Given this list of marker genes KLF10, SGK1, TGIF1, TRIM13, ACKR4, RRP12, NXF1, HBA2, RMDN3, AREG, CD52, SRA1, PADI3, C9orf40, TMPRSS2, TCP10L, GJB3, DNAJB8, STAT6, TCF12, SOX5, SEC11C, PTDSS2, SLC1A1, TNFAIP8L1, CXCL2, PDGFB (platelet derived growth factor subunit B), MAP3K2, ELF4, ADAM22, HAND2, CNP, RYK, COQ10A, GTF2B, JUN, PPP4R2, TUT7, SLC4A8 (solute carrier family 4 member 8), ARID3B, SYT5, SCNM1, CLIP2, VMP1, PCSK7, RAC3, NECAP1, ZNF532, RASL11B, SLC18A3, C15orf39, TBP, LAMC2, CLASRP, GCH1, TGFB1, MSLN, METAP2, PTPRJ, ICA1, SLC29A2, IRF7, SNX17, IRAK1, ADGRE5, NFYC, XCR1, CLPX, ZNF639, CDK2, ABCD2, HSPA1A, CLEC4F, SLC35D1, RABGGTA, SOX1, CST3, SLC20A1, RNF166, RNF19A, MMP15, ELMOD3, MOGAT2, CUBN, EMP3, VCAM1, DNAJC5, MAGEH1, PRDX5, KCNA3, SIN3B, PTPN6, BUB3, HDHD5, RHOB (NCBI Gene Id 388), LRPAP1, RPL6, TXNL4A, SF3B5, PMPCA, PCBD1, ADRA2B, FIBP, RANBP3, MTCH2, ZFP14, PRSS8, SNIP1, EMC6, CDH9, WBP1, CD7, KLF6, FLOT2, NF2, OMP, HPD, TBX2, ITGA2, COMMD4, INO80C, BPIFA2, NEFM, METTL18, EEF2, PAX1, DOHH, NUDCD2, C1QBP, SPPL3, ARHGEF2, ARL4C, TXNIP, HLA-DMB, MAN2B1, OAZ1, DBNDD2, DUSP1, GREM1, NAB2, VPS37B, GIPC1, THOP1, C19orf73, SEMA4D, HSD17B12 (NCBI Gene Id 51144), EEF1AKMT1, SLC25A25, COL4A3, TUBB2A, MRPL46, MRPL16, TOMM70, CSF2, BCL2A1, VRK1, NR4A1, CXCL14 (C-X-C motif chemokine ligand 14), CCN5, PARN, PPP2R5C, CITED2, CNPY2, TNIP1, DNAH8, SSNA1, NAPSA, RAB4B, SPPL2B, NLK, HAUS4, GDI1, B3GALT4 (NCBI Gene Id 87866), TMEM222, MVK (mevalonate kinase), MC3R, DPT, GLYR1, CDC42EP4, SIX1, MCUR1 (NCBI Gene Id 63933), PPP5C, BSN, PLAUR (plasminogen activator, urokinase receptor, NCBI Gene Id 5329), TNF, RSRP1, ACOX1, PSMG1, DNMT3A, GAP43, CHRNG, PRM3, ACOD1, IFRD1, CHCHD3, CPSF2, PPP2R5A, NR2C2AP, PTPN23, MIX23, here is a description of the gene set: species: Homo sapiens Genes down-regulated in CD4 T helper cells (20h): Th0 versus TGFB1 and IL6. from publication Yosef N, Shalek AK, Gaublomme JT, Jin H, Lee Y, Awasthi A, Wu C, Karwacz K, Xiao S, Jorgolli M, Gennert D, Satija R, Shakya A, Lu DY, Trombetta JJ, Pillai MR, Ratcliffe PJ, Coleman ML, Bix M, Tantin D, Park H, Kuchroo VK, Regev A (PMID 23467089) Human Gene Set: GSE43955_TH0_VS_TGFB_IL6_TH17_ACT_CD4_TCELL_20H_DN Despite their enormous importance, the molecular circuits that control the differentiation of Th17 cells remain largely unknown. Recent studies have reconstructed regulatory networks in mammalian cells, but have focused on short-term responses and relied on perturbation approaches that cannot be applied to primary T cells. Here, we develop a systematic strategy – combining transcriptional profiling at high temporal resolution, novel computational algorithms, and innovative nanowire-based tools for performing gene perturbations in primary T cells – to derive and experimentally validate a temporal model of the dynamic regulatory network that controls Th17 differentiation. The network is arranged into two self-reinforcing and mutually antagonistic modules that either suppress or promote Th17 differentiation. The two modules contain 12 novel regulators with no previous implication in Th17 differentiation, which may be essential to maintain the appropriate balance of Th17 and other CD4+ T cell subsets. Overall, our study identifies and validates 39 regulatory factors that are embedded within a comprehensive temporal network and identifies novel drug targets and organizational principles for the differentiation of Th17 cells.